The following is a description of a gene set: Human Gene Set: HE_LIM_SUN_FETAL_LUNG_C1_EARLY_AIRWAY_PROGENITOR_CELL Early airway progenitor from publication He P, Lim K, Sun D, Pett JP, Jeng Q, Polanski K, Dong Z, Bolt L, Richardson L, Mamanova L, Dabrowska M, Wilbrey-Clark A, Madissoon E, Tuong ZK, Dann E, Suo C, Goh I, Yoshida M, Nikolić MZ, Janes SM, He X, Barker RA, Teichmann SA, Marioni JC, Meyer KB, Rawlins EL (PMID 36493756) species: Homo sapiens, and this is the list of marker genes: CYTL1, MTTP, H3-5, CRH, HS3ST1, ZMAT4, LYPD6B, GPC3, GRHL1, GADD45G, FSTL5, PLPP2, CDH2, MOXD1, TMEM178A, SCD, NR2F2-AS1, GABRA1, MEG3, TBX1, MITF (NCBI Gene Id 7487), INSIG1, SPTSSB, ALPL, TOX3, FRMD3, IGDCC3, ADM, ASCL1, PHLDA1, OPRK1, CAMK1D, CTNND2, SRGAP1, XIST, PCDH17, TMEM47, ABCG1, RP1, HSPA6